Given this list of marker genes ENPP2, ANP32A, NUP214, ELAVL1, TNFSF13, SET, XPO1, GPRC5A, PRKCA, PRKCD, here is a description of the gene set: part of: Regulation of mRNA stability by proteins that bind AU-rich elements studied in species Homo sapiens HuR (ELAVL1) is a ubiquitous protein that binds AU-rich elements in mRNAs and acts to stabilize the mRNAs. HuR activity is controlled by phosphorylation, with PKC alpha and PCK delta enhancing the ability of HuR to bind and stabilize mRNAs. Binding of mRNAs occurs in the nucleus and HuR then interacts with the CRM1 export pathway to transfer the mRNA to the cytoplasm. The mechanism by which HuR shields the mRNA from degradation is unknown.<br>HuR also regulates translation of some mRNAs, in some cases repressing translation and in some cases enhancing translation of bound mRNAs by recruiting them to polysomes.<br>HuR binds and regulates mRNAs encoding Cyclooxygenase-2 (COX2, PTGS2), Cyclin A (CCNA, CCNA2), Cyclin D1 (CCND1), Cyclin B1 (CCNB1), CD83 antigen (CD83), and proto-oncogene c-Fos (FOS).<br>HuR is a member of a family of proteins that also contains HuD (ELAVL4), HuB (ELAVL2), and HuC (ELAVL3). HuB, HuC, and HuD are specifically expressed in neural tissue.<br>HuR participates in apoptosis. During lethal stress HuR becomes mostly cytoplasmic and is a target of Caspase-3 and Caspase-7. The cleavage products of HuR in turn promote apoptosis. Reactome Pathway: HuR (ELAVL1) binds and stabilizes mRNA